Given this list of marker genes WDR44, LRATD1, EMCN (endomucin), TTC29, C11orf58, ALDH1A2, LMOD1, YWHAB, APPL1, ARHGAP26, F8A1, BORA, KIRREL1, SHISA7, USP37, HPS5, BAZ2B, RANBP10, ADGRF3, UNC80, GPALPP1, ADCYAP1, COA5, PKD2, NBR1, SPRED3, INHBC, ZNF347, ALG10B, SERPINB10, ARPP19, FOS, C1orf43, COLEC11, ZEB2, LAMTOR3, CST8, TOX3, RTL3, P4HA1, GCH1, STEEP1, CNTN3, ARHGAP42, TAOK1 (NCBI Gene Id 80214), here is a description of the gene set: from publication Chen Y, Wang X (PMID 31504780) Genes predicted to be targets of miRBase v22 microRNA hsa-miR-490-5p in miRDB v6.0 with MirTarget v4 prediction scores > 80 (high confidence targets). species: Homo sapiens Human Gene Set: MIR490_5P